Given this list of marker genes CDKN2D, RPS15A, RPS11, TMSB10, SCNM1, HNRNPU, ATP13A2, PDLIM1, VIM, RPS12, RPLP2, S100A13, RPL12, LSM3, NME2, CD44, here is a description of the gene set: studied in species Homo sapiens Human Gene Set: HOLLEMAN_VINCRISTINE_RESISTANCE_B_ALL_DN from publication Holleman A, Cheok MH, den Boer ML, Yang W, Veerman AJ, Kazemier KM, Pei D, Cheng C, Pui CH, Relling MV, Janka-Schaub GE, Pieters R, Evans WE (PMID 15295046) Genes distinguishing vincristine resistant and sensitive B-lineage ALL; here - genes down-regulated in the drug resistant samples. Childhood acute lymphoblastic leukemia (ALL) is curable with chemotherapy in approximately 80 percent of patients. However, the cause of treatment failure in the remaining 20 percent of patients is largely unknown.